The following is a description of a gene set: species: Homo sapiens Transcription factors and DNA binding proteins enriched at promoters of genes whose expression fluctuates during the cell cycle (pVal < 0.05) and peak in M in K562 Transcription regulation during the cell cycle is crucial for ensuring genes are expressed at the right time and in the correct amounts, coordinating key processes like DNA replication, mitosis, and cell division. In our study, Human Gene Set: PULVER_FOREY_CELLCYCLE_ENRICHED_TFS_M, and this is the list of marker genes: NSD2, NR2F1, L3MBTL2, GABPB2, ELF1, KLF1, MAZ, ZNF263, EGR1, ZIC2, GTF2I, ZNF319, FOXJ3, POLR2A, SMARCA4, ZNF281, SP4, ADNP, HDAC1, HDAC2, ZNF467, HMGN3, ZNF334, ZNF770 (NCBI Gene Id 54989), CXXC5, CHD4, ARID2, VEZF1, MAX, KDM5B, KLF10, TFAP4, SMARCE1, PCBP1, KLF14, PHF8, HNRNPL, E2F6, IKZF1, CCNT2 (NCBI Gene Id 905), MYNN, ZBTB7A, BCOR, SP1, GMEB1, ARID1B, RBFOX2, ZMYM3, ZNF148, ZFX, ZFP36, KDM1A, DPF2, ZNF3, ZNF436, RAD21 (NCBI Gene Id 5885), SMARCA5, ZNF740, NFIC, ZNF282, NRF1, MTA2, MNT, HDGF, GABPB1, RCOR1, ZNF540, RNF2, GTF2F1, POLR2G